Given this list of marker genes EFNA1, FLT1, PARP9, FGF10, CNOT7, VPS25, TNFSF18, HES1, FER, SFRP2, DMTN, ENPP2, LILRA5, ZFYVE28, ABL1, INPP5F, HRG, RAP2B, PTK2, CD80, IL18, PTPN6, FLT3, EFNA5, MVP, IGF1R, BLK, MAPK3, ZGPAT, PRLR, GPRC5A (G protein-coupled receptor class C group 5 member A), KIT, LIF, NEDD9, IFNL4, ABI3, PDGFRB, FES, CTF1, IL20, THBS4, SRMS, DOK7, ERBB4, TNK2, ARL2BP, ABL2, CSPG4, EGFR, CADM4, ANGPT1, CASS4, SNX6, GPRC5B, PDCL3, FGFR2, FGFR4, IL11, PTK2B, IL12A, ALK, KDR, LTK, SOCS4, LYN, ANGPT4, SRC, FLT4, DYRK1A, FGFR1, IL21, PIBF1, PTK6, ITGB2, ERRFI1, LCK (NCBI Gene Id 95387), ADAM17, FYN, CNTF, ARHGEF2, OSM (oncostatin M), EPHA7, EPHA3, LACRT, FGR, TGFB1, TTBK1, CHMP6, BTK, EPHB2, ABI1, SRCIN1, ABI2, TPST2, UNC119, IFNL1, FGFR3, PARP14, SFRP1, RAP2C, PDGFRA, TNFRSF18, IL15, IL31RA, PTPN2, IFNG, IL6, HCK, EFEMP1, TSG101, VEGFB, NRG1, SAMSN1, FGF7, PTPN1, ZAP70, VEGFA, NTRK1, BANK1, CSF1R, PDGFB, DDR1, RIPK2, SOCS5 (NCBI Gene Id 9655), JAK2, EPHA4, PKDCC, SYK, DDR2, JAK3, ERBB2, here is a description of the gene set: Human Gene Set: GOBP_PEPTIDYL_TYROSINE_MODIFICATION studied in species Homo sapiens The modification of peptidyl-tyrosine.